The following is a description of a gene set: Mouse Gene Set: GOBP_POSITIVE_REGULATION_OF_ACTIVIN_RECEPTOR_SIGNALING_PATHWAY studied in species Mus musculus Any process that activates or increases the frequency, rate or extent of the activity of any activin receptor signaling pathway., and this is the list of marker genes: Acvr2a, Csnk2b (NCBI Gene Id 13001), Acvr1b, Nodal (nodal growth differentiation factor), Acvr2b, Fgf9, Zc3h3, Synj2bp